The following is a description of a gene set: studied in species Mus musculus part of: Regulation of insulin secretion electronically inferred by orthology from the curated human pathway This event has been computationally inferred from an event that has been demonstrated in another species.<p>The inference is based on the homology mapping from PANTHER. Briefly, reactions for which all involved PhysicalEntities (in input, output and catalyst) have a mapped orthologue/paralogue (for complexes at least 75% of components must have a mapping) are inferred to the other species. Reactome Pathway: Adrenaline,noradrenaline inhibits insulin secretion, and this is the list of marker genes: Gng4, Gng8, Gng3, Gng5, Gnb5, Gnb3, Gng7, Gnb2, Gngt2, Gng10, Adra2a, Adra2c, Gng11 (guanine nucleotide binding protein (G protein), gamma 11), Gnai1, Adcy5, Gngt1